Given this list of marker genes SLC38A1, RAB3A, SYNE1, SOWAHA, FCGRT, FAM78A, CCNI, GALNT12, PRXL2A, FGL2, VEZT, MBLAC1, TMEM119, CHSY1, ECSIT, GTF2I, ARHGDIB, RSPH1, TDRP, EPSTI1, NUP88, LRTM2, SPATA6L, TPCN1, FASLG, ZNF865, TMEM141, GPR22, SRGAP3, CRYBB1, FHAD1, GUCD1, NAGK, PPP6R2, KCNT2, SUCNR1, TGFBR2, ZFP42, GRAMD1A, MSL3, ARRB2, NOD1, INPP1, IL24, HAPLN1, VPS18, ACAT2, TMEM247, PPP1R13B, BVES, SLC22A7 (solute carrier family 22 member 7), SLC34A1, SEPTIN6, CDK2AP2, ARHGAP36, GZMA, PIK3AP1, SORCS3, SNAI3 (snail family transcriptional repressor 3), ATXN2L, SELENOT, GDPD1, LYPD6, MCTP2, RPS19, GALNT9, SMIM3, COQ8B (coenzyme Q8B), MSS51, LYPD6B, GFPT2, YTHDF1, SRPK1, NLRC3, ALPK2 (alpha kinase 2), OSBPL3, CCDC191, PAPSS1, CELF4, ZNF251, GGT1, GOLT1A, HYDIN (HYDIN axonemal central pair apparatus protein), CPLANE2, ABI3, CDYL2, ELK3, MS4A18, CP, PRM2, CCDC6, GABRA5, C15orf48, FNTB, ANKLE1, BBS9 (Bardet-Biedl syndrome 9), PRAP1, TSN, RCBTB2, TXLNA, MAPRE2, KIF21B, RNF10, SHLD1, HRC, HMGCS2, PI4KA, NTRK3, ADH1C, HLTF, SPSB2, FAAH, TGM6 (transglutaminase 6), SLC10A2, PPP4R2, SLC35G1, PROM1, CPSF4, FAM227B, RPS18, RAPGEF4, COL12A1, PRR5L (proline rich 5 like), ZIM3, NHLH1, LHPP, IPMK, VKORC1, TAF13, CNGA1, MED22, RPS16, NRG1, ABCB6, ZNF652, RIOX2, QPCT, PRDX6, HOXA9 (NCBI Gene Id 94575), LRFN5, GTF2A1L, FREY1 (NCBI Gene Id 143678), SNX5, DLX4, ST8SIA1, COA5, PLA2G7, AGO1, STAC, SYCP1, NGLY1, PRDM16-DT, POU2AF1, STXBP5, NR3C1, DHRS11, TBX6, EVI2A, PI4K2A, RPA1, SCML4, MFSD14B, LRRC75B, CRYBG3, TP53TG5, UTP14A, KIF2B, RER1, PKNOX1, TUBB, NAT8L, CDKL3, ATP13A4, STK17B, GNGT2, EZH1, OIP5, STAB2, MAP4K4, DSE, PRKAG3, LPAR6, GNPTG, F12 (coagulation factor XII (Hageman factor)), SLC30A7, KRTAP26-1, RPE65, FHIP1B (NCBI Gene Id 84067), ARMC7, LGALS3, PPEF2, RBM20, BCS1L, DLX2, CDH20, MFSD9, ZNF8, RPS8 (ribosomal protein S8), KMT5A, PLTP (NCBI Gene Id 5360), here is a description of the gene set: CD4(+)Foxp3(+) regulatory T (Treg) cells originate primarily from thymic differentiation, but conversion of mature T lymphocytes to Foxp3 positivity can be elicited by several means, including in vitro activation in the presence of TGF-beta. Retinoic acid (RA) increases TGF-beta-induced expression of Foxp3, through unknown molecular mechanisms. We showed here that, rather than enhancing TGF-beta signaling directly in naive CD4(+) T cells, RA negatively regulated an accompanying population of CD4(+) T cells with a CD44(hi) memory and effector phenotype. These memory cells actively inhibited the TGF-beta-induced conversion of naive CD4(+) T cells through the synthesis of a set of cytokines (IL-4, IL-21, IFN-gamma) whose expression was coordinately curtailed by RA. This indirect effect was evident in vivo and required the expression of the RA receptor alpha. Thus, cytokine-producing CD44(hi) cells actively restrain TGF-beta-mediated Foxp3 expression in naive T cells, and this balance can be shifted or fine-tuned by RA. Human Gene Set: GSE13306_TREG_VS_TCONV_LAMINA_PROPRIA_DN from publication Hill JA, Hall JA, Sun CM, Cai Q, Ghyselinck N, Chambon P, Belkaid Y, Mathis D, Benoist C (PMID 19006694) Genes down-regulated in comparison of regulatory T cell (Treg) versus conventional T cells activated with lamina propria dendritic cells. studied in species Homo sapiens